Given this list of marker genes ARHGEF5, PHB2, ADCY1, ALK, RNF31, CAMK1D (NCBI Gene Id 57118), TRIM13, TRIM8, MTDH, NEUROG1, CLOCK, CARD9, TNFSF18, TRIM31, NEUROD2, PPIA, RPS3, TSSK4, S100A12, MID2, S100A8, FOXA1 (forkhead box A1), STING1, ERC1, TRIM32, ZC4H2, ADCY8, PRKCI, CD40LG, RIPK1, RPS6KA5, RBCK1, TRIM22, BCL10, TCF3, TLR2, CRTC2, DHX9, TRIM26 (NCBI Gene Id 7726, tripartite motif containing 26), TRIM38, TRAF5, CEBPG, RAB7B, TRIM27, PRKCH, CARD16, PRKD2, CARD14, NLRC4, DHX33, DDR2, NOD2, PRKCZ, EPHA5, AGER, ANXA3, CRNN, ESR2, NLRP3, ROR1, TRIM14, CLU, TNF, IKBKB, BTK, MYD88, FANK1, ZBTB7A, IL18R1, EP300, IL18, FER (NCBI Gene Id 2241), PYCARD, LGALS9, ESR1, SPHK1, RIPK3, MAP3K13, HSPA1B, TRAF2, DDIT3, CAMK2A, PRKCQ, TRIM52, ZIC2 (NCBI Gene Id 7546), DDRGK1, NPM1, RPS6KA4, NEUROG2, RHEBL1, TRIM25, MTPN, CARD11, TRIM62, SYT14P1, TRIM34, AIM2, COPS5, CHUK, TRIM37, TRIM5, RELA, ARID5B, TFDP1, PRKD1, EIF2AK2, HSPA1A, ARHGEF2, SRF, RNF25, KIT, TLR4, TRIM15, TRAF1, RNF220, RIPK4, TERF2IP, UBE2N, IL18RAP, TRAF6, CRTC1, LTF, IRAK1, S100A9, TRIM21, RTKN2, NEUROD1, NTRK1, ATF2, NOD1, PRDX3, CIB1, IKBKG, here is a description of the gene set: Human Gene Set: GOBP_POSITIVE_REGULATION_OF_DNA_BINDING_TRANSCRIPTION_FACTOR_ACTIVITY studied in species Homo sapiens Any process that activates or increases the frequency, rate or extent of activity of a transcription factor, any factor involved in the initiation or regulation of transcription.